The following is a description of a gene set: studied in species Homo sapiens Human Gene Set: GOBP_CALCIUM_ION_TRANSMEMBRANE_TRANSPORT A process in which a calcium ion is transported from one side of a membrane to the other by means of some agent such as a transporter or pore., and this is the list of marker genes: TRPV3, DMD, MICU3, SESTD1, ITPR2, LIME1, CACNA1C, UCP2, LYN, SLC8A1, SLN, TSPAN13, ATP2C2, PTK2B, CACNG3, TPCN2, TMEM165 (NCBI Gene Id 55858), TLR9, CXCR3, CNGB1, CASQ1, MCOLN2, TRPM1, APLNR, ORAI3, GRIN1, ITGB3 (integrin subunit beta 3), CLIC2, TRPC6, CRACR2A, PTPRC, NIPSNAP2, PRKCE, PKD1L2, GRINA, BHLHA15, PKD1, FGF2, PSEN2, VMP1, PLCL1, CALM3, CACNA1E, HTR2B, NPPA, GHITM, HAP1, LETM1, TRPC4, CALHM1, SLC24A4, PPP3CC, PKD2L2, TRPC7, STRIT1, CXCL10, CORO1A, PANX3, TRPM2, STIM2, TRPA1, F2, P2RX4, GRIN2A, RYR2, CHD7, MCOLN3, ATP2C1, SLC8A2, WNT3A, TGFB1, PMPCB, MCUR1, SLC8B1, CD19, CATSPER1, CACNG8, TMBIM4, PPP3CB, SLC24A3, PDE4D, FASLG, CACNA2D2 (NCBI Gene Id 9254), MIR133A1 (NCBI Gene Id 406922), RYR1, CACNG4, BCL2, NPSR1, CCR7, CCL21, BAX, MIR93, FAIM2, CACNG2, ITGAV, CUL5, LETM2, GRIN3B, PDE4B, TPCN1, GSTM2, BDKRB1, ANO9, CALM1, PANX1, PLCH1, EDN1, CACNA1I, GP9, ATP2B4, P2RX3, PDPK1, TRPC4AP, FLNA, TRPV4, AKAP6, GPM6A, SEC61A1, HTR2A, CACNA1F, ERO1A (NCBI Gene Id 30001), MAIP1, GP1BA, TRPC3, ATP1B1, GPER1, METTL21C, SRI, ASPH, GSTO1, G6PD, TRDN, PIK3CG, NALCN, SLC8A3, MIR328, MIR1-1, RGS9, CNGA1, GRIN2C, KCNN4, MS4A1, JPH3, ATP2B3, STAC3, DHRS7C, DDIT3, CD4, CACNA1A, MIR208B, KCNK16, CALM2, CALHM3, P2RX2, HSPA9, FKBP1B, CATSPER3, THY1, CAPN3, CACNA1B, TRPM8, CACNB4, CACNA1G, MIR208A, AHNAK, SLC35G1 (NCBI Gene Id 159371), ORAI2, CACNG5 (NCBI Gene Id 27091), PLCH2, PLCB1, P2RX5, CYBA, MCU, TMEM38B, GRM6 (NCBI Gene Id 2916), ATG5, MICU1, AKAP5, TRPV2, GRIN2B, CAMK2D, SUMO1, CACNB3, NOS1, JPH1, SCN11A, PLCB4, AFG3L2, MIR21, YWHAE, GP5, MCOLN1, EDNRB, PPP3CA, UBASH3B, SPG7, CXCL9, P2RX1, PRNP, CACNA1D, CCL19, CACNG7, CACNA2D3, REM1, LACRT, ANO6, PRKD1, UBR3, TRPC1, PKDREJ, PSEN1, TRPM4, PLCB3, JPH2, PLN, TMC2, PLCE1, PLA2G1B, SLC24A1, NCS1, NALF1, SNCA, TRPC5, TRPV1, PLCG1, CAV1, CNGA3, CHERP (NCBI Gene Id 10523), STIMATE, TRPM6, GNB5, PKD1L3, CACNG1 (calcium voltage-gated channel auxiliary subunit gamma 1), GAS6, NOL3, CXCL11 (NCBI Gene Id 6373), F2R, CNGA4, CACHD1, MCUB, TMEM37, ADCYAP1R1, GRIN3A, NTSR1, PPP3R2, ANK2, PRKACA, CACNB1, CHRNA10, GRXCR1, TRPM3, DRD2, GPR35, UBQLN1, BIN1, STIM1, PLCL2, CACNA1S, TMCO1, GRIN2D, STAC, CNGA2, PML, SLC25A25, IBTK, ITPR3, NALF2, STAC2, TMEM38A, TRPV6, MIR499A, PKD2, FKBP1A, ATP2A1, TMBIM1, SELENON, P2RX7, CHRNA7, CCL3, KCNJ8, CATSPER2, RYR3, BAK1, MIR200C, FYN, HTT, NGF, DRD1 (NCBI Gene Id 1812), CACNA1H, ASIC1, ITPR1, SLC24A5, CBARP, JPH4, ATP2B2, CRHR1, IL13, DIAPH1, NOS1AP, LCK, PTPN6, CACNA2D4, CACNB2, CACNA2D1, ABL1, TMBIM6, P2RX6, APP, ATP2A2, VDAC1, CACNG6, XCL1, CATSPER4, TOR2A, F2RL3, CX3CL1 (C-X3-C motif chemokine ligand 1), EPO, PPP3R1, OPRM1, HPCA, PKD2L1 (NCBI Gene Id 9033), CALCA, EDNRA, ATP2A3, TRPV5, HRC, PLCB2 (NCBI Gene Id 5330), XCR1, CASQ2, PLCG2, P2RY6, ORAI1, FMR1, SMDT1, TRPM7, SLC25A23, CEMIP, SLC24A2, TMC1, ATP2B1, CHRNA9, GP1BB, CCR5, ATP1A2, TRPM5, HTR2C, MICU2, PKD1L1